The following is a description of a gene set: In this study, an extensive analysis was conducted to define meta-programs (MPs) capturing intra-tumor heterogeneity across a spectrum of tumor types. The approach utilized non-negative matrix factorization (NMF) to analyze each cell type separately within individual tumor samples. This involved the analysis of malignant cells, macrophages, fibroblasts, endothelial cells, epithelial cells, T-cells, and B-cells. NMF was executed with varying parameter values (K=4, 5, 6, 7, 8, 9), thereby generating 39 programs for each cell type per sample. Each NMF program was summarized by the top genes based on NMF coefficients.\nRobust MPs were then delineated for each cell type using a set of stringent criteria, including recurrence within the same tumor, similarity to programs in other tumors, and non-redundancy within a tumor. Subsequently, these robust NMF programs were clustered (per cell type) based on Jaccard similarity, leading to the identification of MPs associated with each cell type.\nTo enhance the quality of the MPs, a refinement steps were undertaken, involving the removal of MPs suspected of reflecting low-quality data (with an overrepresentation of ribosomal proteins or mitochondrial-encoded genes), single-study inclusion, or similarity to miss-annotated cell types. from publication Gavish A, Tyler M, Greenwald AC, Hoefflin R, Simkin D, Tschernichovsky R, Galili Darnell N, Somech E, Barbolin C, Antman T, Kovarsky D, Barrett T, Gonzalez Castro LN, Halder D, Chanoch-Myers R, Laffy J, Mints M, Wider A, Tal R, Spitzer A, Hara T, Raitses-Gurevich M, Stossel C, Golan T, Tirosh A, Suvà ML, Puram SV, Tirosh I (PMID 37258682) Human Gene Set: GAVISH_3CA_METAPROGRAM_CD8_T_CELLS_UNASSIGNED_1 studied in species Homo sapiens Genes upregulated in subsets of cells of a given type within various tumors, and this is the list of marker genes: HLA-DRB1, TRAF3IP3, POLR2J3, EVL, CMC1, GIMAP4, SH2D1A, MBNL1, DDX17, MBP, SYNE2, GIMAP1, LCK (LCK proto-oncogene, Src family tyrosine kinase), ARGLU1, GCC2, PRPF38B, RNF213, SAMD3, PRP4K (NCBI Gene Id 8899, pre-mRNA processing factor kinase PRP4K), PTP4A2, RESF1, IL7R, KLRB1, PIK3IP1, TXNIP, TBC1D10C, PNISR, KLRG1, GPSM3, NKTR, CAP1 (cyclase associated actin cytoskeleton regulatory protein 1), PLEK, IKZF3, FYB1 (NCBI Gene Id 55458), N4BP2L2, ATRX (NCBI Gene Id 6475), ITGB2, STK17A, UCP2, TRGC2, GZMK, HLA-F, GIMAP7, LIMD2, CD27, BTN3A2, APMAP, AKAP9, MPHOSPH8, PPP1R18